Given this list of marker genes SCARA3, SSC5D, DMBT1, ACKR2, ENPP2, VTN, ACKR3, ACKR4, PRG4, LRP1, CD36, CD163, SCARF2, LGALS3BP, EGFEM1P, MEGF10, MSR1, ENDOU, COLEC12, CXCL16, ENPP1, STAB2, AGER, STAB1, SCARB1, SCARB2, SCARF1, here is a description of the gene set: Combining with any modified low-density lipoprotein (LDL) or other polyanionic ligand and delivering the ligand into the cell via endocytosis. Ligands include acetylated and oxidized LDL, Gram-positive and Gram-negative bacteria, apoptotic cells, amyloid-beta fibrils, and advanced glycation end products (AGEs). Human Gene Set: GOMF_SCAVENGER_RECEPTOR_ACTIVITY studied in species Homo sapiens